The following is a description of a gene set: part of: Response to metal ions The MTF1:zinc complex in the nucleus binds Metal Response Elements (MREs), DNA containing the core consensus sequence 5'-TGCRCNC-3', and activates or represses transcription depending on the context of the MRE. The 6 zinc fingers of each MTF1 monomer have different affinities for zinc and evidence from the mouse homolog indicates that different concentrations of zinc, and hence different metal loads in MTF1, activate different subsets of target genes. Genes activated by MTF1 include those encoding metallothioneins, zinc transporters, and stress-response proteins. studied in species Homo sapiens Reactome Pathway: MTF1 activates gene expression, and this is the list of marker genes: CSRP1, SNCB, MTF1